The following is a description of a gene set: Genes down-regulated in CD8 T cells: stem cell memory versus effector memory. An early-differentiated CD8+ memory T cell subset with stem cell-like properties (TSCM) can be identified within the naïve-like T cell population by the expression of CD95/Fas. Based on experiments including exon- and gene-level expression analysis, we provide evidence that this subset of antigen-specific cells represents an early precursor of conventional central (TCM) and effector (TEM) memory CD8+ T cells with enhanced self-renewal capacity and proliferative potential. We identified genes differentially expressed between major T cell subsets defined along with memory T cell commitment. Based on the analysis of these genes, CD95+ naïve T cells (TSCM) cluster closer to the CD8+ T memory compartment than to classical (CD95-) naïve T (TN) cells, and display an intermittent phenotype between classical TN and TCM cells in terms of all major T cell differentiation markers analyzed. from publication Gattinoni L, Lugli E, Ji Y, Pos Z, Paulos CM, Quigley MF, Almeida JR, Gostick E, Yu Z, Carpenito C, Wang E, Douek DC, Price DA, June CH, Marincola FM, Roederer M, Restifo NP (PMID 21926977) species: Homo sapiens Human Gene Set: GSE23321_CD8_STEM_CELL_MEMORY_VS_EFFECTOR_MEMORY_CD8_TCELL_DN, and this is the list of marker genes: SMARCB1, CCNA2, VAPA (VAMP associated protein A), STK10, PCF11, SF1, TUBGCP2, RYBP, UBA3, CEBPB, ERCC1, UBE2S, ELP4, COPB1, OARD1, ERCC4, PLEK, ATP6V1G1, CHRNA6, LPIN1, SLC39A14, RAB33A, IMPDH1, MSL1, MAPK3, SOCS1, MICU2, BCL7B, TUBA1A, GBE1, GOT1, KPNB1, SLC25A5, COL14A1, MDN1, S100A11, ABCD3, SATB1 (NCBI Gene Id 6304), FEM1C, SF3A1, NUP50, PDS5B, N4BP1, IL1R1, TSPAN6, PIEZO1, TUBGCP3, MAPK7, RBM14, TUT4, REXO5, JTB, ESYT1, ALDOA, CD63 (CD63 molecule), CCL8, TRIP13, KLF6 (KLF transcription factor 6), PEX3, P4HB, EIF2S2, BICD2, DYNC1I2, ATP5F1A, MYOF, GNAI3, TDP2, JARID2, RSRP1, IST1, KIF23, CYLC1, SLC25A14, IL4R, FNTA, SDCBP, DLG5 (NCBI Gene Id 9231, discs large MAGUK scaffold protein 5), PTPN18, MYH9, FKBP2, PGRMC1, LRP5, ARCN1, KCNAB2, BCL2A1, SPINT2, SLBP, MIA2, GPR183 (NCBI Gene Id 1880), TAX1BP1, GARS1, UPP1, ISCU, ZFP36, PDXK, IRF4, ITPR3, GNA13, MLF2, YBX3, CEP68 (NCBI Gene Id 23177), CDKN2D, ITGB1, TFDP1, CA2, EXOSC8, UBB, EML2, GPNMB, IMP4, PLTP, RRM2, LAPTM4A, COX7B, HDAC4, VDAC2 (NCBI Gene Id 7417), IL10RA, PJA2, TNFAIP3 (NCBI Gene Id 7128), MAP3K14 (mitogen-activated protein kinase kinase kinase 14), GNAI1, DSTN, ACLY, PSMG1, RAN, SLC7A1 (solute carrier family 7 member 1), DYNLT1, TMEM59, MEF2C, PDK3, MAP4, H1-10, AP4S1, KIF11, GTF3C1, RNF11, FURIN, PRPS1, PLD3, PSMD8, RBL2, GNE, TMF1, RAC1, SRSF4, UPF3A, RASGRP1, MRPL33, SOD1, SLC7A5, DLD, LYPLA1, CDC37, BDKRB1, CDH3, HTATSF1, RAB27A, DDR2, SNU13, HERC3, DPYSL2, R3HCC1L, RGS19, KHDRBS1, STK17B, TOPBP1, STXBP2, RNF14, PRPSAP2, RAB14, CD28, RAP1B, VDR, PTTG1IP, TCEA1, ATP5MJ, PRRC2C, AFF1, GNA15, SSBP1, MDH1, DESI2, UQCRQ, FLNA, ARF6, ZFR, GRAMD1B, FRMD4B, UBE2D2, JUNB, UNC50, NSL1 (NCBI Gene Id 96380), ETFA, FOSL2, PHF3, NDUFAF1, TBCA, RABEPK, BCLAF1